Given this list of marker genes Ppp3ca, Cdkl5, Ilk, Chrnb2, Abl2, Sult4a1 (sulfotransferase family 4A, member 1), Ptprf, Igf2bp1, Pten, Adgrb3, Pafah1b1, Dlg4, Stk11, Taok2, Nlgn3, Fbxw8, Caprin2, Myo5b, Met, Cacna1a, Abi3, Hecw2, Btbd3, Abi2, Itgb1, Mink1, Chrna3, Dbn1, Tmem106b, Efna1, Slc30a1, Itpka, Pdlim5, Vldlr, Dpysl5 (dihydropyrimidinase-like 5), Cux1, Zfp365, Prex2, Cntnap2, Ube3a, Lrp8, Nedd4l, Slitrk5, Atp7a, Sdc2, Ptn, Farp1, Ephb3, Abi1, Sipa1l1 (signal-induced proliferation-associated 1 like 1), Camk2b, Rere, Sema3a, Tlx2, Dscam, Lrrk2, Lrp4, Klf7, Ephb1, Septin7, Akap5, Abitram, Slc11a2, Actr3, Cask, Trpc6, Dip2a, Arhgap44, Robo1, Trpc5, Phactr1, Fbxo31, Grip1, Wls, Rbfox2, Mapk8, Cit, Pak3, Celsr2, Atg16l1, Adam10, Wnt5a, Rac1, Cdk5, Mfn1, Gorasp1, Dact1, Nr2e1, Camk2a, Ctnna2, Fzd4, Kalrn, Numbl, Cc2d1a, Sgk1, Tnik, Dcdc2a, Ache, Actr2, Mef2a (myocyte enhancer factor 2A), Abi3bp, Dvl1, Lzts3, Skor2, Wnt7a, Dcx, Picalm, Elavl4, Tet1, Opa1, Ptprz1, Wasl, Nfatc4, Nedd4, Sh3glb1, Tanc2, Cux2, Dhx36, Dclk1, Hprt1, Cdk5r1, Cul7, Tbc1d24, Bhlhb9, Numb, Ptprd (protein tyrosine phosphatase receptor type D), Trak1, Rapgef2, Tpbg, Id1, Afdn, Fyn, Pqbp1, Mfn2, Kif1a, Cacna1f, Ctnnd2, Ankrd27, Ywhah, Trak2, Kndc1, Gsk3b, Hdac6, Eef2k, Dnm1l, Pias2, Zdhhc15, Cdkl3, Dbnl, Lzts1, Dnm3, Xlr3b, Stau2, Shank3, Ppfia2, Kidins220, Nlgn1, Arc, Srcin1, Prmt3, Hecw1, Anapc2, Sema4d, Reln, Sarm1, Rab21, Caprin1, Dtnbp1, Epha4, Cdc42, Ngef, Parp6, Obsl1, Il1rapl1, Ephb2, Mapk8ip2, Rap2a, Rock2, Shank1 (SH3 and multiple ankyrin repeat domains 1), Marcks, Baiap2, Ppp1r9a, Nsmf, Chrna7, Map6, Grin1, Tiam1, Cfl1, Arhgap33, Dock10, Epha5, Neurog3, Ss18l1, Nrp1 (neuropilin 1), here is a description of the gene set: studied in species Mus musculus Mouse Gene Set: GOBP_DENDRITE_MORPHOGENESIS The process in which the anatomical structures of a dendrite are generated and organized.